Given this list of marker genes Cd200l1, Zbtb14, Prim1, Mrpl46, Slfn4, Nkain2, Rnft1, Rab33a, Otud1, here is a description of the gene set: from publication Chen Y, Wang X (PMID 31504780) Mouse Gene Set: MIR_7223_3P Genes predicted to be targets of miRBase v22 microRNA mmu_miR_7223_3p in miRDB v6.0 with MirTarget v4 prediction scores > 80 (high confidence targets). studied in species Mus musculus